The following is a description of a gene set: Human Gene Set: HP_ABDUCENS_PALSY studied in species Homo sapiens Abducens palsy Malfunction of the abducens nerve as manifested by impairment of the ability of the affected eye to be moved outward. Patients who develop abducens nerve palsy often present with binocular horizontal diplopia, which is a double vision when looking at objects side by side. There will be a notable weakness of the ipsilateral lateral rectus muscle leading to a deficit in of eye abduction on the affected side. Some patients may present with a constant head turning movement to maintain binocular fusion and to lessen the degree of diplopia., and this is the list of marker genes: TMEM67, TBC1D2B, MEN1, PSAP, MYMK, WDR26, CDH23, TRPV4, ABCB7, CCDC174, NAXE, AIP